The following is a description of a gene set: A complex comprised of DNA wound around a multisubunit core and associated proteins, which forms the primary packing unit of DNA into higher order structures. Mouse Gene Set: GOCC_NUCLEOSOME studied in species Mus musculus, and this is the list of marker genes: H2al1b, Noc2l, Glyr1, H3f4, H2aj, Shprh, Yeats4, Kdm1b, H2ac13, H2bc22, H4c9, Ep400, Brd8, Mphosph8, H2ac6, H2ac23, H3c7, H2ac12, H3c10, Macroh2a1, H3c14, H2bc18, H2al1f, H4c18, H2ac11, H2az2, Tgm2, Kat5 (K(lysine) acetyltransferase 5), H3f3b, Meaf6, Kat6b, H2bw2, H2ac1, H2bc1, H1f9, H2bl1, H1f4, H2al1m, Actb, Actl6a, Tnp2, H2ac21, H2ac7, H3c8, H2ab3, Morf4l2, H2bc12, H2ab2, Ruvbl2, H3c4, H2al1n, H2al1o, H4c14, Ing3, H1f3, Tnp1, H2ax, H2ac25, H3c2, Prm2 (protamine 2), H2ac24, H2al2b, Morf4l1, H4c3, H2al3, Slf1, H4c16, Dmap1, H4c17, H1f8, Kat6a, Cenpa, H3c3, Prm3, H2ac15, H4c11, Epc2, H2ac4, Irf4, H3c11, H2bc21, H1f5, H2al1e, H4c6, H1f6, H3c13, H1f1, Mrgbp (MRG/MORF4L binding protein), H3f3c, H2bc3, H4c12, H2bc9, H2ac10, H4c4, Mbtd1, Hp1bp3, Sphk2, H2ab1, Macroh2a2, H2ac22, Tcf3, H3c6, H2al1j, H2ac20, H2bc14, H2al1k, H2bc27, H2ac19, Trrap, Ruvbl1, Vps72, H2ac8, H4c1, H2al2a, H1f0, Prm1, Actr6, H3c1, H1f2, H2az1, H2bc26, Znhit1, H3f3a, Epc1, H4c2, H4c8, H2ap, H3c15